Given this list of marker genes Adra1a, Mkks, Nppb, Gnas, Npy, Crh, Drd3, Ffar3 (free fatty acid receptor 3), Prcp, Bbs4, Pik3r1, Nppa, Kcnk6, Adra1d, Adrb3 (adrenergic receptor, beta 3), Vegfc, Gch1, Oxt (NCBI Gene Id 18429), Trpv1, Oprl1, G6pdx, Nedd4l, Ier3, Drd5, Ppara, Bmpr2, Tac1, Calca, Adora1, Ucn, Glp1r, Tnf, Apln, Bdkrb1, Gpr37l1 (G protein-coupled receptor 37-like 1), Gja5, Adrb1, Adipoq, Rnpep, Rnls, Mas1, Snx5, Tac4, Ptafr, Arhgap42, Nos3, Sod2, Hrh3, Smtn, Guca2b, Abcc9, Nos2, Agtr2, Drd2, Cnr1, Agt, Nos1, Uts2r, Bdkrb2, Kdr (NCBI Gene Id 269657), Mrgprd, Pmch, Adrb2, Ntsr1, Abat, Adm2, Ahr, Scpep1, Kl, Uts2, here is a description of the gene set: studied in species Mus musculus Any process in which the force of blood traveling through the circulatory system is decreased. Mouse Gene Set: GOBP_NEGATIVE_REGULATION_OF_BLOOD_PRESSURE